Given this list of marker genes Tmed2, Paqr3, Insig1, Zbtb7b, Spring1, Amfr, Insig2, here is a description of the gene set: Any process that modulates the frequency, rate or extent of the SREBP signaling pathway. species: Mus musculus Mouse Gene Set: GOBP_REGULATION_OF_SREBP_SIGNALING_PATHWAY